Given this list of marker genes LINC01538, TFF3, RRN3P3, ZNF184, CFL2, CREM, DTWD1, IDI1, NUDT15, PFKFB3, MIR17HG, FUT8-AS1, EXOC2, TMEM132D-AS1, FAM98A, SAP30L-AS1, DUSP4, NFE2L2, SLC2A3, EGR3, MRPS18A, CDC42EP1, ZNF718, NR4A1, HPGDS, KCTD19, MGC4859, ZBTB8A, BMS1P1, GGACT, ZNF222, ATG101, PPAN, OPCML (NCBI Gene Id 4978), ISG20L2, DNAJB9, LINC01116, SPI1, FAM200A, LEKR1, ZPR1, PPP1R3C, RABIF, FBXL13, ENC1, ITPR2, MUC7, SLCO4C1, NFKBID, RAB40A, SLC31A1, SERINC5, UFSP1, SLC24A3-AS1, YIPF4, TAGAP, TXNDC15, ZNF143-AS1, ZNF778 (NCBI Gene Id 650330), KLK6, BTN2A2, RAD54B, GPR183, CMC2, EGR2, NKAPL (NFKB activating protein like), ARHGDIG, GMNN, RPRML, ALG13, PKHD1L1, PCP4L1, DUSP2, DOCK4, BTG2, TRMT10C, SLC25A12, RBSN, TMEM126A, GLTPD2, IBA57, THUMPD3-AS1, CYTIP, SDR42E1, CNTNAP1, BCOR, HSF5, S100A2, SMARCA1, RUFY2, MRPL27 (NCBI Gene Id 64988), ZNF672, FYCO1, RPA3, AP5B1, EVI2A, ZNF200, SESN3, IER2, ETV3, ICOS, KLF10, ARL5B, TASL, AREG, WDR33, SELENOS, SLC17A6, SLC9A5, TEX30, GCK, NR4A3, DCTN4, UMPS, GADD45B, PRSS12, CD69, MAN1A2, PRPF38A, MSI1, LIAT1, LAG3, PTRH2, PRAME, SELENOK, KRT14, ZNF383, PAF1, SRSF1, FBXO33, USH2A, OR51B4, PANX1, EGR1, UQCC4, PKD1L2, LGALS4, RD3, ZNF571 (zinc finger protein 571), RAPGEF4, SLC30A1, CLDN9, AHI1-DT, CEP192P1, RASGEF1B, ANKHD1 (ankyrin repeat and KH domain containing 1), KPNA2, HCP5, CHST13, TNFRSF10A-DT, LINC00907, SNRNP35, GPR18, FABP7 (NCBI Gene Id 2173), LRRC63, GPR65, YOD1, FBXO30, PPM1D, CRNKL1, NBPF8, PIK3CB, RASL11B, ZNF331, OSBPL1A, TNF, HEXIM1, H1-6, AK9, PNPLA8, ZBTB49, CHD1-DT, ANKRD37, IER5, COL17A1, GJA1, IFRD1, NAA30, SLC52A3, TXNRD1, FGF21, BCL2A1, NR4A2, STARD6, SPRY1, YRDC, MRPS25, CKS2, GEM, ZNF410, MYL2 (myosin light chain 2), HTN3, here is a description of the gene set: Human Gene Set: GSE17974_0H_VS_0.5H_IN_VITRO_ACT_CD4_TCELL_DN from publication Elo LL, Järvenpää H, Tuomela S, Raghav S, Ahlfors H, Laurila K, Gupta B, Lund RJ, Tahvanainen J, Hawkins RD, Oresic M, Lähdesmäki H, Rasool O, Rao KV, Aittokallio T, Lahesmaa R (PMID 20620947) studied in species Homo sapiens The aim of this dataset was to study in detail the transcription kinetics initiated by cytokine IL-4 in early differentiation of Th2 cells. Genes down-regulated in comparison of untreated CD4 T cells at 0 h versus the untreated cells at 0.5 h.